Given this list of marker genes Slc30a5, Slc30a1, Slc39a8, Slc30a10, Trpm2, Slc39a5, Slc30a3, Slc39a10, Slc30a8, Slc39a13, Slc39a12, Slc30a2, Slc1a1, Slc39a1, Slc39a2, Tmem163 (NCBI Gene Id 72160), Trpm7, Slc30a4, Slc39a6, Slc39a9, Pik3c2a, Slc39a4, Slc39a3, Slc30a6, Ap3d1, Slc39a14, Slc39a11, Slc39a7, Mt3, Slc30a9, Slc30a7, here is a description of the gene set: Mouse Gene Set: GOBP_ZINC_ION_TRANSPORT studied in species Mus musculus The directed movement of zinc (Zn II) ions into, out of or within a cell, or between cells, by means of some agent such as a transporter or pore.